Given this list of marker genes ENSG00000294121, RN7SL647P, CLUHP10, VPS51P4, TMEM183AP5, HNRNPA3P8, RNU6-1129P, CNTN3, RNU6-386P, MRPS17P3, EVA1CP5, HNRNPA3P6, OR7E22P, NIPA2P2, SETP6, SRRM1P2, UNC93B3, CAP1P1, HYDINP1, OR7E55P, RNU6-217P, LINC00506, RN7SL294P, RN7SKP61, MYLKP1, LINC02027, AKR1B1P2, LSP1P2, LINC02018, DUX4L26, RNU2-28P, LINC02050, CADM2, SNRPCP10, FAM86DP, ENPP7P2, CYP51A1P1, MIR1324, PPATP1, ALG1L6P, RPL7AP23, HSP90AB5P, FRG2C, VDAC1P7, HMGB1P38, GBE1, ENSG00000201410, LINC02070, LINC00960, CADM2-AS1 (CADM2 antisense RNA 1), LINC00971, MIR4444-2, MIR3923, RN7SKP284, ZNF717, THAP12P2, RPL23AP49, LINC02025, MIR4273, OSBPL9P1, LINC02077, RARRES2P1, AGGF1P3, VGLL3, MIR5688, ROBO1, ROBO2, CADM2-AS2, LINC02008, OR7E121P, ENSG00000304080, RPS12P6, RN7SL751P, RPS3AP15, ENSG00000298601, OR7E66P, here is a description of the gene set: Human Gene Set: chr3p12 species: Homo sapiens